Given this list of marker genes Ep300, Ptpn6, Ptn, Mdk, Alkal2, Irs1, Alk, Jak3, Hdac3, Shc1, Pik3r2, Pik3cb, here is a description of the gene set: This event has been computationally inferred from an event that has been demonstrated in another species.<p>The inference is based on the homology mapping from PANTHER. Briefly, reactions for which all involved PhysicalEntities (in input, output and catalyst) have a mapped orthologue/paralogue (for complexes at least 75% of components must have a mapping) are inferred to the other species. Reactome Pathway: Signaling by ALK studied in species Mus musculus electronically inferred by orthology from the curated human pathway part of: Signaling by Receptor Tyrosine Kinases